The following is a description of a gene set: Mouse Gene Set: GOMF_DNA_ENDONUCLEASE_ACTIVITY_PRODUCING_5_PHOSPHOMONOESTERS studied in species Mus musculus Catalysis of the hydrolysis of ester linkages within deoxyribonucleic acids by creating internal breaks to yield 5'-phosphomonoesters., and this is the list of marker genes: Endov, Dnase1l1, Apex1, Dna2, Gen1, Dnase1l3, Fan1, Dnase1 (NCBI Gene Id 13419), Exo1, Slx1b (NCBI Gene Id 75764), Fen1, Dicer1, Dnase1l2